Given this list of marker genes Rock2, Cd59a, Fgfr4, Fgfr1, Ccm2l, Stat5b, Heg1, Wnt11, Aif1, Ptgs2, Rgcc, here is a description of the gene set: The appearance of a fibroblast growth factor due to biosynthesis or secretion following a cellular stimulus, resulting in an increase in its intracellular or extracellular levels. species: Mus musculus Mouse Gene Set: GOBP_FIBROBLAST_GROWTH_FACTOR_PRODUCTION